The following is a description of a gene set: part of: Signaling by NOTCH1 in Cancer NOTCH1 PEST domain mutations are frequently found in T-cell acute lymphoblastic leukemia (T-ALL). PEST domain mutations interfere with ubiquitination-mediated NOTCH1 downregulation and result in prolonged half-life of the intracellular NOTCH1 fragment, NICD1, and increased NICD1 transcriptional activity. Reactome Pathway: Signaling by NOTCH1 PEST Domain Mutants in Cancer species: Homo sapiens, and this is the list of marker genes: SNW1, HDAC11, HDAC7, UBB, MAML3, NEURL1B, HDAC8, NOTCH1, JAG2, RPS27A, HDAC3, CUL1, HEY1, SKP1, RBX1, HDAC9 (histone deacetylase 9), NCOR2, HEYL, MAML1, HDAC1, EP300, PSEN1, NCOR1, UBC, JAG1, HDAC5, TBL1XR1, MAML2 (mastermind like transcriptional coactivator 2), HDAC6, ADAM17, DLL1, PSENEN, APH1A, MIB2, HDAC10, FBXW7, KAT2B, CCNC, MYC, RBPJ, TBL1X, HDAC2, DLL4 (delta like canonical Notch ligand 4), UBA52, HEY2, MAMLD1, KAT2A, HDAC4, CDK8, ADAM10, NCSTN, PSEN2, MIB1, HES1, APH1B, CREBBP, HES5, NEURL1